The following is a description of a gene set: from publication Xie X, Lu J, Kulbokas EJ, Golub TR, Mootha V, Lindblad-Toh K, Lander ES, Kellis M (PMID 15735639) Genes having at least one occurrence of the highly conserved motif M42 TGACATY in the regions spanning 4 kb centered on their transcription starting sites. The motif does not match any known transcription factor binding site. Human Gene Set: TGACATY_UNKNOWN Comprehensive identification of all functional elements encoded in the human genome is a fundamental need in biomedical research. Here, we present a comparative analysis of the human, mouse, rat and dog genomes to create a systematic catalogue of common regulatory motifs in promoters and 3' untranslated regions (3' UTRs). The promoter analysis yields 174 candidate motifs, including most previously known transcription-factor binding sites and 105 new motifs. The 3'-UTR analysis yields 106 motifs likely to be involved in post-transcriptional regulation. Nearly one-half are associated with microRNAs (miRNAs), leading to the discovery of many new miRNA genes and their likely target genes. Our results suggest that previous estimates of the number of human miRNA genes were low, and that miRNAs regulate at least 20% of human genes. The overall results provide a systematic view of gene regulation in the human, which will be refined as additional mammalian genomes become available. species: Homo sapiens, and this is the list of marker genes: PBXIP1, KCNH2, CNIH3, ZNF521, XKRX, KBTBD12, LITAF, HAPLN2, TBL1X, ASCC3, DPF2, PDK4, SH3BGR, ACMSD (aminocarboxymuconate semialdehyde decarboxylase), NEUROD6, BMI1, QRFP, LEMD1, OTOP2, WDTC1, STN1, FOXP2, PPP1R1B, IL13, DPF3, ACSBG2, NCK2, P2RX3, SKA2, TJP1, SOBP, PTPRC, ALLC, KCNAB1, KCNN2, MSRB3, MYLK (NCBI Gene Id 50483), MAP7D1, APBB2, CNN3, CALM1, AGTR1, FRMD4A, SLK, VASP (vasodilator stimulated phosphoprotein), DVL1, AOC2, TRPV6, MYO7A, LGSN, STARD13 (StAR related lipid transfer domain containing 13), DNAJC14, RBM14, PTPRD, ITGBL1, HSD11B1, PURA, MEOX2, TAGAP, ERN1, HBS1L, PRR5L, FAM78A, CLPTM1 (CLPTM1 regulator of GABA type A receptor forward trafficking), TEX44 (testis expressed 44), CALHM4, AP3S1, ACVR1C, FGFR2, RELA, CDRT4, PHOX2B, NKAPD1, KCNK18, MFSD14A, DAAM1, ASB4, SLC3A2 (NCBI Gene Id 6520), TNFRSF8, MAP2, MAP3K14, CNN1, PPP2R5B, SAP30L, SELENON, DMD, MYOZ2, KCNK1, C12orf42, OSBPL7, KLF14, TRPM1, GAB2, CRLS1, WNT3, TSHB, TECTA, BARHL2, NAP1L3, H3-3B, LIMS1, MAPK10, FSTL5, FGF19, ARHGAP4 (Rho GTPase activating protein 4), SLN, ASB11, MLLT3, PDGFRA, DTD2, PTPN1, LPXN, COL6A3, MEIS2, MID1, APH1A, FYN, RAB8B, NDST2 (NCBI Gene Id 8509), FOS, CYP7B1, TMUB2, NOS1AP, CCDC138, PRR16, FGFR3, PLCE1, WIPI1, ATG12, FAM133A, NFATC4, C1orf43, TMEM132E-DT (NCBI Gene Id 400591), PPTC7, LMX1B, RNF19A, BIRC6, TPM3, TRIM9, HECTD1, TTN, RGS6, ST13 (NCBI Gene Id 8937), GPR162, FSCB (NCBI Gene Id 84075), CREBZF (CREB/ATF bZIP transcription factor), NTS, HAPLN1, HCN4, OMA1, PDGFA, COL4A5, CABLES1, ZMYND8, PLOD2, CD8A, TENM1, PLBD1, ESM1, BCL11A, MBIP, ATOH7, IRAG2, LPP, HERC2, GPR85, CORO1A, KLF9, CACNA1G, CLC, CCL22, CFTR, CABP7, TTC39C, HAND1, CALM2, PSME4 (NCBI Gene Id 23198), STT3B, ANKS1B, TPRG1, STEAP4, MEF2C, CD247, CEBPB, FAM81B, SNX17, UCMA, CA12, MANEAL (mannosidase endo-alpha like), ADRA1B, MCAM, IL9, FAM219A, NPAS3, CDK13, RUNX1T1, SLC25A35, PYGM, GREB1L (NCBI Gene Id 80000), ARHGAP30, LINC00649, FHL3, DSC2, SPACA7, BARHL1, AJUBA, SPI1, ITM2B, RAPGEF6, IKZF4, CDR2L, GBP5, TMEM178A, FEZF2, SYT13, CCDC22, ADAM11, EYA1, MOB4, DNAJB4, RUNX1, GSK3B, OLFM4, ALDOA, CSPP1, IGF1, POLE2, MSTN, ITK, SPTBN2, MADD, MICAL2, STAT3, GPR55, DDR1, FAM53C, TTC17, CYP26A1, RAP1GDS1, HYAL1, TBC1D8, CD68, WDR64, IRX3, AKAP5, OTP, FAM162A, TNFSF12-TNFSF13, LLCFC1, ABL1, LSM5, MYLIP, ELOF1, SESN3, DNAH7, JUN, LMOD3, TMEM62, CLCN5, PRR11, DNAI1, CAVIN2, SLC9A2, SCHIP1, STK32C, SCN8A, CACNA1D, RNF38, LRMDA (leucine rich melanocyte differentiation associated), LMTK2, GDAP1L1, TP53INP2, DOCK11, ZBTB47, SCP2D1, RASA3, BMPR2, HLA-DOB, DNAJC1, HOOK1, CDC42EP3, NUDT4, TBL1XR1, HOXB8, PPP1CC, IGFBP6, HTR3A, NR2F2, SPOCK2, DLG2, TTBK2, SYNE2, CCDC54, GUCA1C (NCBI Gene Id 9626), EMSY, MAP1B (microtubule associated protein 1B), CLTB, BCAS2, BSDC1, ARHGEF3, SLC24A4, HIVEP3, MITF, PIK3R1, CDIN1, DICER1, AMOTL1, ZBTB32, SNX14, ESRP2, C5orf46 (NCBI Gene Id 389336), SKP2, TRIT1, ENPP2, NONO (NCBI Gene Id 8253), FGF12, BMP8B, DNAJC5B, RNF148, PDE4D, ORC4, MYT1 (NCBI Gene Id 4661), HIPK1, NPPC, SPMIP8, AKAP3, RILP, CCDC6, TSPAN4, CHERP, TRIM54, SS18, BAIAP2L1, POU3F4, KRT31, PPP1R3A, ELMO1, MEIS1, CCSER2, CDK6, SAT1, CFAP65, EHD1 (EH domain containing 1), PCSK2, LIN54, TGM1, ABI3BP, SLC4A1, PDZD2, ZBTB4, SCN3B, COMMD3, QPCT, FGF10, SFMBT1, CSRNP1, CELF3, PRKAR2B, CELSR3, ATXN1, GASAL1, PAFAH1B1, ABR, RTTN, ZRANB1, NFIL3, C22orf31, BCHE, CRX, C18orf54, SLC44A5 (solute carrier family 44 member 5), MEMO1, FAM83F, MDH1, ZBTB18, CDC42EP4, BIN3, RAB21, RBFOX1, VKORC1L1, CREM, TAGLN, ARHGEF6, RBBP6, FLRT3 (fibronectin leucine rich transmembrane protein 3), AKIRIN2, SPDYE1, USH1G, APBA1, EBF2, ATP6V0C (NCBI Gene Id 527), KIRREL2, GRIA4, GALNT15, SPEG, STMN4, RUNX3 (NCBI Gene Id 864), TFDP2, GNG3, TIAL1, RBM10, ZKSCAN5 (zinc finger with KRAB and SCAN domains 5), WBP1L, GABRR1, ZNF654, CHD4, MNT, COQ8B, LRP1, RNF14, KIF13B, ERG, SLC16A6, MCHR1, PDE1C, LRP1B, DUSP10, LIFR, NEBL (NCBI Gene Id 51739), CXCL6, SORBS1, WSB2, GAS7, ENSG00000204117, ADARB2, RRAD, HOXC12, PPFIBP1, CFL2, VEZF1, KMT2C, LRRN2, MXRA8 (matrix remodeling associated 8), PTH, HABP2, METTL9, DAPK3, ADCY6, RND2, SLC35G3, CTSC, TENM3-AS1, AKAP4 (NCBI Gene Id 8852), ARAP2, C1QTNF4, HOXC6, XPNPEP3, SELE, CDH10, RARB (retinoic acid receptor beta), MKNK2, TNFSF12, MAG, PCBP1, ATP6V1A, KRAS, RPA2, INPP4A, CYLD, MARCHF10, POLR2A, C1orf116, FAM170A, NT5C1B, TGFB2, ERCC6L2, WIPF1, RFX4, LRFN5, IL17B, UNC5C, BLNK, ATP2B3, FBXO32, CUZD1, TPPP2, NR3C1, LMO3, TNNI3K, IL22, UNC13D, ASB17, ACTL7A, CD27, NTF4, CHCHD7, SYNCRIP, BSND (NCBI Gene Id 7809), ATP5F1A, DENND2B, TLK2, INSM1, RPS2P45, NXPH1, EIF2B4, PRDM1, ZIC1, MEX3D, PDZRN4, PELI2, EFEMP1, INPP4B, KBTBD8, ASXL1, TNFRSF21, ATP5MG, SLITRK6 (SLIT and NTRK like family member 6), KRTAP13-2, ERBB3, AKAP12, MYOT, NECTIN3, AP2A2, ZHX2, ADTRP, ADAMTS12, SEPTIN4, RNF11, SASH1, TTF2, FGF23, NOVA2, ZFHX3, KIAA0586, CSNK1G2-AS1 (CSNK1G2 antisense RNA 1), ARF6, EVA1C (NCBI Gene Id 59271), SLITRK5, OLFM1, SEL1L, TNFRSF19, TACC2, HOXD10, SBF1, SLF2, SNCAIP, TLX3, ZIC4, COX5A, SCN7A, FBXO36, IQGAP3, TP63, ITPKC, TRIM8, FAIM2, PRMT3, LEPROTL1, PITPNC1, GABRG1, PAK6, DUSP3, MBNL1, SLC38A6 (NCBI Gene Id 145389), ANGPTL2, SPRR1A, ATP1B1, CSMD3, CTDSPL2, NFATC1, KRT36, GPR22, JARID2, PLAG1, NKX2-2, CALD1, TIMM9, YPEL4, FAM186B, DCAF7, IGSF3, PARP6 (poly(ADP-ribose) polymerase family member 6), ABCB8, RAPSN, GEM, CTNND2, ASGR1, CBFA2T2, FOXN3, SORBS3, TGFBR1, TSC22D1, DCX, SPAG6, TSHZ3, SNX12, GOLPH3L, LTBP1, TSHZ2, CATSPER2, DNAJC13 (NCBI Gene Id 285196), LHX3, LRRN4CL, CALHM5, ST3GAL1, ARHGAP24, PICALM, TET2, ELOVL5, ARHGEF39, NHLH2, SMPD3, CCDC50, RAB1A, ZNF485, SLC18A2, HOXC10, RORB, ADGRG4, DMP1, LARGE1, POLR2L, DCDC1, ZFP91, ARMCX4, IQCF1, LCAT, FBXW11, CITED2, CTNND1, SULF1, BDNF, CCDC141, AGO2, CLDN20, CPNE1, C5, EGFR, MYOCD, NCDN, IGF2R, MAP7, SYT4, SPAG5, TFAP2D, CD40LG, PEX7, STX6, MOSPD1, HNRNPA3, SLC6A5, ITPRIP, SLC2A4, FOXG1, SH2D4A, COL4A6, FGD4, BCL2, PTHLH, FGF8, NDST4, TRPC4AP, COX14, NPVF, ADGRB2, PPM1A, HOXA10, PPP2R5C, RCAN2, GARIN1B, BSCL2, SGK2, PDIA3, HOXB3, HNRNPD, ARHGAP12, FXYD1, FAXC, OLIG2, DES, NRP2, ACAP3 (NCBI Gene Id 80855), TEX2, SCRT2, STAC2, RAB30, ELAVL4